The following is a description of a gene set: studied in species Mus musculus Mouse Gene Set: GOBP_REGULATION_OF_POSTSYNAPTIC_NEUROTRANSMITTER_RECEPTOR_INTERNALIZATION Any process that modulates the frequency, rate or extent of endocytosis of neurotransmitter receptor at the postsynapse., and this is the list of marker genes: Rabep1, Pick1, Sirt2, Hip1, Vac14, Cblb, Mdm2, Hpca, Akap5 (A kinase anchor protein 5), Tamalin, Rnf216, Rala, Lrp1, Synj1, Efnb2, Numb, Drd3 (dopamine receptor D3), Hap1, Rnf220, Arc, Lpar1, Pip5k1c, Ppp3r1, Pacsin1, Usp46, Tspan7, Scrib, Itgb3, Syt17, Nrg1, Atad1, Nedd4, Ncdn, Ophn1, Drd4, Nedd4l, Iqsec1, Susd4, Gsg1l